The following is a description of a gene set: Mouse Gene Set: GOBP_URATE_TRANSPORT studied in species Mus musculus The directed movement of urate into, out of or within a cell, or between cells, by means of some agent such as a transporter or pore., and this is the list of marker genes: Slc17a1, Slc2a9, Abcc4, Umod, Slc22a12, Slc17a2, Slc17a3, Slc22a13, Abcg2, Slc23a1, Slc17a4